Given this list of marker genes IL13, CD300LF, SHPK, ALOX15, IL13RA2, here is a description of the gene set: species: Homo sapiens Any process that results in a change in state or activity of a cell (in terms of movement, secretion, enzyme production, gene expression, etc.) as a result of an interleukin-13 stimulus. Human Gene Set: GOBP_CELLULAR_RESPONSE_TO_INTERLEUKIN_13